Given this list of marker genes Avpr1a, Ube3a, Avp, Car2, Car7, here is a description of the gene set: Mouse Gene Set: GOBP_POSITIVE_REGULATION_OF_CELLULAR_PH_REDUCTION species: Mus musculus Any process that activates or increases the frequency, rate, or extent of a process that reduces the internal pH of a cell.